The following is a description of a gene set: Mouse Gene Set: GOMF_GUANYLATE_CYCLASE_ACTIVITY studied in species Mus musculus Catalysis of the reaction: GTP = 3',5'-cyclic GMP + diphosphate., and this is the list of marker genes: Gucy2e, Guca2b, Gucy2d (guanylate cyclase 2d), Gucy2c, Guca1b, Gucy1b1, Gucy2f (NCBI Gene Id 245650), Npr1, Ncs1, Gucy1a1, Gucy2g, Npr2, Gucy1b2, Gucy1a2, Guca1a, Nherf4, Guca2a